The following is a description of a gene set: Comprehensive identification of all functional elements encoded in the human genome is a fundamental need in biomedical research. Here, we present a comparative analysis of the human, mouse, rat and dog genomes to create a systematic catalogue of common regulatory motifs in promoters and 3' untranslated regions (3' UTRs). The promoter analysis yields 174 candidate motifs, including most previously known transcription-factor binding sites and 105 new motifs. The 3'-UTR analysis yields 106 motifs likely to be involved in post-transcriptional regulation. Nearly one-half are associated with microRNAs (miRNAs), leading to the discovery of many new miRNA genes and their likely target genes. Our results suggest that previous estimates of the number of human miRNA genes were low, and that miRNAs regulate at least 20% of human genes. The overall results provide a systematic view of gene regulation in the human, which will be refined as additional mammalian genomes become available. from publication Xie X, Lu J, Kulbokas EJ, Golub TR, Mootha V, Lindblad-Toh K, Lander ES, Kellis M (PMID 15735639) Genes having at least one occurrence of the highly conserved motif M62 SMTTTTGT in the regions spanning 4 kb centered on their transcription starting sites. The motif does not match any known transcription factor binding site. Human Gene Set: SMTTTTGT_UNKNOWN studied in species Homo sapiens, and this is the list of marker genes: FUS, NDP, LRRN4CL, EDEM3, BTK, GABRA2, SPIN1, ZNF706, EDN3, SLFN11 (schlafen family member 11), YRDC, CILK1, PCBP2, ARID4A, ARL4C, RBM5, CXXC4, HOXA5, IRAK1, FKBP5, PNRC2, PDGFB, SAFB, SRSF5, MBNL1, NIPBL, DLG2, ETS2, KIF1B, FBN2, DDX3X, MEIS2, ITGB4, POU6F2, KATNBL1, HOXD12, AKAP8, MYO10, CD180, NEUROD1, FOXP1, PRICKLE3 (prickle planar cell polarity protein 3), JADE1, EPN1, NLGN3, IPO11, OMG, HPCAL1, NHLH2, ZNF503, PANK3, USP44, TMED9, SATB2 (NCBI Gene Id 80104), CRKL, EPC1, ZNF143, JARID2, IL11RA, PTGS1, ATP5F1A, CPEB4, ITPK1, FLRT3, ARHGEF17, LRP1, APLN, ENPP2 (ectonucleotide pyrophosphatase/phosphodiesterase 2), GPR12 (G protein-coupled receptor 12), DDX3Y, ROGDI, GATA2, DUSP4, SCUBE3, FGFR4, SLC10A1, GNAQ, KCNH7, ZBTB11, LRRC4, IKZF2, SP8, MAP1B, TAB2, SCG3, EIF4G2 (NCBI Gene Id 1982), GLYR1, YWHAE, DMD, RCOR1, RBM4B, GNAO1, LCP1, CSNK1A1, GGN, PRR34, RRAS2, ILF3, ESRRA, HNRNPA1 (NCBI Gene Id 780920), TTL, FGF8, LMO4, PCDHA11, DSTN, H1-10, PPP2R2B, DHRS3, MTSS1, ZNF436-AS1, WBP4, CDAN1, CNN3, SPRR4, ZMYM2, YWHAQ, PROX1, ETV1, GPR85, CD4 (NCBI Gene Id 920), TFAP2D, COLCA1, C1orf122, MOG, MID1, CSAD, RAB33A, CRYGC, TIAM1, SHH, BLOC1S1, FZD5, DDX17, PCF11, RBM3 (NCBI Gene Id 5935), STC1, TCF4, GPR173, NIN, SOX3, DMPK, HAPSTR1, LMOD1, NFIX, ATCAY, YWHAG, ZBTB32, GLRA2, ALDOC, KYAT1, AKAP8L, RIPOR1, MAGED1, PURA, GATM, GPC3, KDM2A, PCYT1B, CRYGA, ARPC2, PDE4D, CXCR4, XKRX (XK related X-linked), PRKAG1, ZNF512, CTTNBP2NL, CLASP1, NOX4, BMX, CITED2, CHTOP, DIO3, CALD1, HOXC6 (NCBI Gene Id 3223), TLK1, DPF3, USP49, PIAS1, HOXD9, RNF44, EPB41L1, FRAS1, CYP26C1, TRIM8, SMAD1, MKRN1, SRGAP2, BCL11A, FRS2, CCR7, HNRNPC, ATP8B4, PP2D1, KIRREL3-AS3, JADE2, ZNF232, ERG (ETS transcription factor ERG), LUC7L3, LHX9, MIR9-1HG, TUBB2B, DAAM1, SLC3A2, BACH2, LHX3, EPN2, DDX6, HOXD4, SLC7A1, SRSF3, TGIF1, GSE1, SYCP2L, GPM6A, HS3ST4, KLF12, ILF3-DT, TCF7, POU2F1, NF1, PREX1, WNT9A, CCAR1 (NCBI Gene Id 55749), TRERF1, RBFOX1, NRG1, SMOC2, VCPKMT, NRF1, LRMDA, ITPR1, NR4A2, RAB10, KCTD15, PELI2, PRR14L, ZBTB14, RBM12, CDK2AP1, IDH2, PIEZO2, MAP4K2, HEXIM2, CHST14, RBMX, RNF43 (NCBI Gene Id 54894), FAM53C, CHD2 (chromodomain helicase DNA binding protein 2), JPT1, EBF1, ZFP36L1, EN1, CADM1, SRGAP1, OGFRL1, SRRM4, GADD45G, EDARADD, PCYT2, MTUS1, GLDN, GPRIN3, NR4A3, SCML1, DDX5, CNKSR2, NF2, CCDC33, MIR7-3HG, BCL6, HOXB5, SET, SEMA4C, FOXN3, ROR1, SS18, HOXD11, ZMYM5, TRA2B, CLK4, KIF2B, DPYSL5, ZNF638, HMGB1, UTP25, MACROH2A1, ATRX, LUC7L2, CBX5, IP6K2, DUSP6, PTP4A1, NEUROG1, TRPM8, ITGB8, MAPK6, P4HA1, NHSL2, STMN1, PPP1R8, ISL1, BMPR2, GSK3B, CACNG3, DAB1, FOXP2, GPR21, CPNE1, HOXA2, CNGB3, MED13, PABPC4, ARRDC1-AS1, NMNAT2, SLC12A8, UNC5C, ANKS1B, MMP14, DOC2B, KANSL1L, ADGRF1, FSBP, DIP2B, COX7B, SLC38A2, CTNND2, PCDH8, ELAVL4, AMMECR1, KIRREL3, LGALSL (galectin like), ID2, RUNX1T1, EHF, KLHL4, CEP95, NOL4L, SLC38A1, ZNF436, CLK1, SRSF2 (serine and arginine rich splicing factor 2), TARDBP, ZNF366, YTHDF2, SFPQ, MSN, KCNK10, IGF1, NTRK2, SP3, JUP, ACVR2A, TNFSF10, APP, HOXA4, SIN3A, MAPKAPK2, LTBP1, TIAL1, ZBTB18, NR6A1, GFPT2, USPL1, CHN1, BTBD9, RYBP, LMO1, UBE2S, HOXB3, KCNN3, ANAPC15, KLF7, DACT3, SOX5 (NCBI Gene Id 6660), ZNF207, TPP2 (NCBI Gene Id 7174), CNOT1, CCNJ, FEZF2, SFSWAP, SLC30A3, SRPK2, MRFAP1, SMPD3, CAMK2G, CDH19, LHX6, QKI, EHD1, OVOL2, NRXN1, LMO3, NEUROD6, ACLY, STX5, OLIG3 (NCBI Gene Id 167826), CLDN2, THUMPD2, CTCF, USP2, ELF5, PLEKHS1, TDRD5, ZCCHC14, SPO11, ONECUT1, PHF12, SOBP (sine oculis binding protein homolog)